The following is a description of a gene set: studied in species Homo sapiens part of: Diseases of hemostasis Reactome Pathway: Defects of platelet adhesion to exposed collagen, and this is the list of marker genes: VWF, GP5, GP1BB, GP1BA, COL1A1, ADAMTS13, GP9, COL1A2